The following is a description of a gene set: Any process that stops, prevents, or reduces the frequency, rate or extent of signaling pathways initiated by the cross-linking of an antigen receptor on a B cell. species: Mus musculus Mouse Gene Set: GOBP_NEGATIVE_REGULATION_OF_B_CELL_RECEPTOR_SIGNALING_PATHWAY, and this is the list of marker genes: Cd300a, Plcl2, Fcrl5, Ptpn6 (NCBI Gene Id 15170), Lpxn, Cd22, Gps2